The following is a description of a gene set: Human Gene Set: GOBP_REGULATION_OF_CELLULAR_RESPONSE_TO_OXIDATIVE_STRESS species: Homo sapiens Any process that modulates the frequency, rate or extent of cellular response to oxidative stress., and this is the list of marker genes: TBC1D24, PNPLA8 (patatin like phospholipase domain containing 8), PINK1, MEAK7, HDAC6, SLC7A11, DHFR, FUT8, MIR132, BMP7, GCH1, SLC25A14, MAPKAP1, ABCD1, NCOA7, FBLN5, PRKN, FADS2, ALOX5, DHFRP1, CD36, AIFM2, NFE2L2, OXR1